The following is a description of a gene set: studied in species Homo sapiens Human Gene Set: HP_PARTIAL_DUPLICATION_OF_THE_PHALANX_OF_HAND A partial duplication, depending on severity leading to a broad or bifid appearance, affecting one or more of the phalanges of the hand. As opposed to a complete duplication there is still a variable degree of fusion between the duplicated bones. Partial duplication of the phalanx of hand, and this is the list of marker genes: RNU4ATAC, PAH, RPS24, RPL31, NUP107, DACT1, GATA1, RPS20, RPS17, RPL11, FGF10, RPL15, FGFR2, RPS27, RPS28, FANCD2, TWIST1, RPL35, SF3B2, DVL1, RPS15A, RPL26, KIF7, RPL35A, RPL27, ADA2, INTU, RPL9, RPS10, TBX5, RPS7, TSR2, HEATR3, SALL1, CHSY1 (chondroitin sulfate synthase 1), PPP2R3C, CANT1 (calcium activated nucleotidase 1), RPS26 (NCBI Gene Id 6231), RPL18, RPS19, RPL8, RPL5, RPS29, GLI1